The following is a description of a gene set: Genes predicted to be targets of miRBase v22 microRNA mmu_miR_6992_3p in miRDB v6.0 with MirTarget v4 prediction scores > 80 (high confidence targets). from publication Chen Y, Wang X (PMID 31504780) species: Mus musculus Mouse Gene Set: MIR_6992_3P, and this is the list of marker genes: Nckap5, Cops7b, Acsm5, Aktip, Ier3ip1, Dnajc27, Wdr33, Acvr1b, Ubxn7, Spred2, Ifnar1, Lrp11, Foxi1, Lcmt2, Pgm1, Abl2, Gja1, Ammecr1l, Eif5, Gja8, Maoa, Ppp1r1c, Ccdc59, Zkscan1, Pramel13, Retreg3, Steap2, Nr3c1, Dnm1, Trib1, Alkal2, Gm266, Arhgap17, Bnip2, Ermard, Glb1l2, Rgp1, Htr2c, Slc39a2, Hmgcs1, Nfatc4, Dnajc16, Alcam (NCBI Gene Id 11658), Cd8a, Zer1, 5730507C01Rik, Atp8b4 (ATPase, class I, type 8B, member 4), Kcns3, Rap1gds1, 1810065E05Rik, Chl1, Slc25a36, Zfp488, Dph5, Sval1, Vps33b, Ccdc82, A430033K04Rik, Fam149b, Aif1l, Cemip2, Sec22b, Rnf152, Ccdc25, Dcc, Fktn, Gpcpd1, Fbxl17, Krtap9-22, Usp13, Gad1, Fzd3, Golm1, Sowaha, Fam117b, Prickle2, Slc9b2, Zwint, Cpxm2, Lrrfip2, Cxcr2, Ctla2a, Rp1, Has2, Nlrp4e, Adsl, Tent5a, Xrcc2, Frmd5, Sertad2, Gpr107, Rragd, Pggt1b, Meltf, Tril, BC051665, Psg19, Mkx, Ino80, Zfp300, Errfi1, Aak1, Pi15, Sp3